The following is a description of a gene set: CRMPs in Sema3A signaling species: Homo sapiens Human Gene Set: REACTOME_CRMPS_IN_SEMA3A_SIGNALING, and this is the list of marker genes: DPYSL3, FES, CDK5, CDK5R1, CRMP1, PLXNA1, PLXNA4, NRP1, FYN, PLXNA3, SEMA3A, GSK3B, DPYSL2, DPYSL5, DPYSL4, PLXNA2